The following is a description of a gene set: Human Gene Set: GOBP_SINGLE_STRAND_BREAK_REPAIR species: Homo sapiens The repair of single strand breaks in DNA. Repair of such breaks is mediated by the same enzyme systems as are used in base excision repair., and this is the list of marker genes: UNG, ERCC8, XRCC1, SIRT1, STK19, APTX, TDP1, ERCC6, LIG4, NEIL3, PARP1, TERF2, APLF, TNP1 (transition protein 1), XNDC1N